Given this list of marker genes UBE3A, PLAA, EIF2B1, ATP10A, OCA2, SNRPN, here is a description of the gene set: Stagnation of head growth seen as flattening of the head circumference curve. studied in species Homo sapiens Human Gene Set: HP_CESSATION_OF_HEAD_GROWTH Cessation of head growth